The following is a description of a gene set: Cytokines mediate cell-cell communication in the immune system and represent important therapeutic targets. A myriad of studies have highlighted their central role in immune function, yet we lack a global view of the cellular responses of each immune cell type to each cytokine. To address this gap, the authors created the Immune Dictionary, a compendium of single-cell transcriptomic profiles of more than 17 immune cell types in response to each of 86 cytokines (>1,400 cytokine-cell type combinations) in mouse lymph nodes in vivo. A cytokine-centric view of the dictionary revealed that most cytokines induce highly cell-type-specific responses. For example, the inflammatory cytokine interleukin-1β induces distinct gene programmes in almost every cell type. A cell-type-centric view of the dictionary identified more than 66 cytokine-driven cellular polarization states across immune cell types, including previously uncharacterized states such as an interleukin-18-induced polyfunctional natural killer cell state. Mouse Gene Set: CUI_TREG_RANKL_RESPONSE_DN studied in species Mus musculus from publication Cui A, Huang T, Li S, Ma A, Pérez JL, Sander C, Keskin DB, Wu CJ, Fraenkel E, Hacohen N (PMID 38057668) Genes negatively differentially expressed in cell type: Treg upon treatment with cytokine: RANKL in mouse lymph nodes in vivo., and this is the list of marker genes: Hspa1b, Dusp1, Junb, Igkc, Hspa1a